The following is a description of a gene set: This SuperSeries is composed of the SubSeries listed below. studied in species Homo sapiens from publication Walker LJ, Kang YH, Smith MO, Tharmalingham H, Ramamurthy N, Fleming VM, Sahgal N, Leslie A, Oo Y, Geremia A, Scriba TJ, Hanekom WA, Lauer GM, Lantz O, Adams DH, Powrie F, Barnes E, Klenerman P (PMID 22086415) Human Gene Set: GSE33425_CD161_HIGH_VS_INT_CD8_TCELL_DN Genes down-regulated in CD8 T cells: KLRB1 high versus KLRB1 int., and this is the list of marker genes: ANXA2, CD96, SMO, FADS1, LGALS1, PRKACB, RPA1, SSX2IP, AIFM1, TXK, RGS10, NDUFA9, TNFRSF18, CELSR1, CYTH3, EBP, FKBP1A, SNHG6, RPS26, NDUFA13, EMB, DLAT, ARL14EP, CTLA4, RAB8B, LMX1B, DBI, KLRK1, NSG2, FUT8, TENT5C, IDH2, MCEE, ITK, STK39, CD7, SAR1B, SFMBT2, RNF149, BLM, HPCAL1, BZW2, UNC119B, ADGRL1, CCL5, PSMB3, SELPLG, IMPA2, TMEM38B, DNAJB6, MEMO1, CD8A, PRIM1, CAPN3, RFC5, CISH (NCBI Gene Id 29917), SEC61G, MRPS28, RACGAP1, ARL4C, TFPI, AMZ2, NAA11, HMGB3, TSPO (translocator protein), POLD2, DHRS4, GMPPB, EZH2, GABARAPL1, TNFRSF9, CD3G, USP3, ADCY6, PRDX6, CD27, TBC1D24, GATD3, TUBB, NUDT1, SVIL, GFI1, SSBP2, ABCG2, PCNA (NCBI Gene Id 5111), POLR2D, PSMA4, PKP4, POLA1, ZSCAN12, SPR, CST7, XDH, PSPH, MYO1F, TKT, PGK1, TXN, C2CD2, MKI67, DAD1, CNDP2, TOP2A, YARS1, SPART, CKS2, VMP1, VPS26B, EPRS1, PSAT1, CENPK, PFKP, FURIN, NEK2, SASS6, ABCB9, ENTREP3, NPC2, ASF1B, GCLM, LCK, PDCD5, OTULINL, RPL41, NABP1, RBM17, GMFB, PSME2, BRIX1, PRKCH (protein kinase C eta), PPIC, DCTPP1, OSTF1, POMP, NOTCH1, GALK1, NBEAL2, PPP2R5C, PDE9A (NCBI Gene Id 5152), GGT1, GALNT2, ITM2C, NR2C2, KIF23, OSTC, S100A11, ACTN1, GARS1, EXOSC7, KLHL9 (kelch like family member 9), BUB1 (NCBI Gene Id 699), CDC6, METTL5, IGF2R, ELOVL6, AP3S1, SH2D2A, PDCD4, LCP2, CD244, SLC35D1, ST3GAL4, ID2, GTF2I, CHMP4B, PELI1, KLRD1, S100A10, SC5D, IDI1, BAX, PRPF38A, PPIA, MEIG1, CD9, NICOL1, CTSD, SARAF, ATP5IF1, YIPF3, NCAPH, UCK2 (uridine-cytidine kinase 2), GPR65, ITGAE, SPRED2, CCND2, PPA1, TCF7, HIBCH, CPE, LMNB1, TTK, PCLAF, AGFG1, SOAT2, MID1, ANAPC13, RWDD1, HAUS3, YJU2